Given this list of marker genes ITM2B, ORC6, ZBTB45, HLTF, DDHD2, HLA-DOA, HES1 (hes family bHLH transcription factor 1), LYL1, R3HCC1, ALDH3A2, FLOT1, HERC1, LSR, UROD, HCK, TPGS2, LY86, TMEM268, SRSF9, TPI1, RGS3, SNRK, IL2RB, CBR3, AMPD3, RAC2, CD164, CENPK, SPTSSA, XPA, CPSF3, RPL24, RNF44, KANSL2, CHKA, EIF4EBP1, ACTR1B, INPP5K, CD47, TRIM28, TSNAX, CDIPT, TRIM41, RFC1, GNG10, ACAA2, ATP5F1C, MAD2L1, KIFAP3 (kinesin associated protein 3), RGL2, FAM114A2, DALRD3, H2AX, ADAM10, PI4KA, SLC44A2, SMAD1, SEPTIN6, FKBP3, ERF, TSKU, VAX2, TWF2, DHX16, CDK5, RNF145, PIP4K2A, ATXN7L3, MFNG, MAPK3, PTPN6, EXOSC5, CLASRP, SLC39A7, CD300C, TFDP1, STAU1, STK10, DGUOK, TUBB, PISD, ANAPC5, MAF1, SAMHD1, KIF16B, BIRC5, RNF166, COX14, RAP1GDS1, MAP3K3, FMC1 (formation of mitochondrial complex V assembly factor 1 homolog), ARID2, PHTF1, CD2BP2, DOCK2, PRDX2, CD6, HK2, TCF19, COMMD7, B4GALNT1, TFEB, UGDH, ABCB1, SCN9A, RRM1, CCDC12, BSCL2 (BSCL2 lipid droplet biogenesis associated, seipin), APOE, IPO7, USP3, RAMP1, KLF4 (KLF transcription factor 4), RNF138, IFNGR1, KIF20A, MDP1, IPO11, PTPRC, FLT3, MTIF2, KIF9, PRKACB, PCLAF, SLC35A1, GSK3A, RAB28, DDHD1, VAC14, TXNDC16, PCYOX1, MACROH2A1, C18orf32, SPATA13, CHUK, GLTP, NCDN, PPIB, RANBP1, TMCO1, CD5, RPS6KA1, MLH1, PRSS8, DAGLB, SUSD6, TMEM229B, CDK4, KLK8, TMEM208, MNS1, PUF60, ARHGAP45, CNDP2, C1QBP, EXOC4, ORMDL3, ZNF362, ECI1, NAV1, POLR2L, SLC25A4, CAPNS1, H1-0, ANAPC11, ITFG1, CLN8, ADI1, EXT2, PLXND1, SLC44A1, PXK, DHRS1, PIM3, LEPROT, JAK3, FGF5, COQ9, CHCHD3, MRPS28, SLC12A2 (NCBI Gene Id 6558, solute carrier family 12 member 2), TBL1XR1, IMP3, AURKA, CORO1B, LTB, LBR, ANP32E (NCBI Gene Id 81611), FOS, DNA2, C6orf136, RFC3, CD2AP, BTG2, HIGD2A, ASCC1, CD302, TRAPPC14, ECH1, CISD1, here is a description of the gene set: Human Gene Set: GSE339_EX_VIVO_VS_IN_CULTURE_CD4POS_DC_UP The functional relationships and properties of different sub-types of dendritic cells (DC) remain largely undefined. We used a global gene profiling approach to determine gene expression patterns among murine splenic CD11c high DC subsets in an effort to better characterise these cells. Genes up-regulated in comparison of ex vivo CD4 dendritic cells (DC) versus cultured CD4 DCs. studied in species Homo sapiens from publication Edwards AD, Chaussabel D, Tomlinson S, Schulz O, Sher A, Reis e Sousa C (PMID 12816982)